The following is a description of a gene set: species: Homo sapiens part of: Gap junction trafficking and regulation Reactome Pathway: Gap junction trafficking Gap junctions are intercellular communication channels formed from Cx (connexin) protein subunits (see Segretain and Falk 2004 and Evans et al. 2006 for comprehensive reviews). Connexins are transported to the plasma membrane after oligomerizing into hexameric assemblies called hemichannels (CxHcs) or connexons. Connexons dock head-to-head in the extracellular space with opposing hexameric channels located in the plasma membranes of neighbouring cells. The double membrane channel or gap junction generated directly links the cytoplasms of interacting cells and facilitates the integration and co-ordination of cellular signalling, metabolism, secretion and contraction. In addition to their role in intercellular communication, connexon hemichannels coordinate the release of ATP, glutamate, NAD+ and prostaglandin E2 from the cells. CxHcs open in response to various types of external changes, including mechanical, shear, ionic and ischaemic stress.<p>The trafficking of gap junctions involves (1) synthesis of connexin polypeptides at endoplasmic reticulum membranes, (2) oligomerization into homomeric- and heteromeric gap junction connexons (hemi-channels), (3) passage through the Golgi stacks, (4) intracellular storage within Trans Golgi membranes, (5) trafficking along microtubules, (6) insertion of connexons into the plasma membrane, (7) lateral diffusion of connexons in the plasma membrane, (8) aggregation of individual gap junction channels into plaques, (9) stabilization of peripheral microtubule plus-ends by binding to Cx43-based gap junctions, (10) internalization of the channel plaque leading to cytoplasmic annular junctions, and (11) complete degradation via lysosomal and proteasomal pathways (see Segretain and Falk 2004). Aspects of gap assembly are described here., and this is the list of marker genes: TUBA4B, GJA1, DNM2, ACTG1, TUBA1A, GJB7, GJC1, GJB4, TUBB3, TUBA4A, TUBA1B, TUBB4B, GJA4, CLTCL1, CLTB, GJB3, CLTA, TUBB8, DNM1, GJA9, GJD3, GJA10, GJA8, GJB6, TUBB8B, TUBB6, TUBAL3, GJB5, GJB2 (NCBI Gene Id 2706), GJC2, TUBB1, ACTB (NCBI Gene Id 60), TUBA8, GJB1, TUBB2B, TUBA3D, AP2M1, DAB2, TUBB4A, GJA5 (gap junction protein alpha 5), GJD2, TUBB2A, GJD4, GJA3, TUBA3E, MYO6, CLTC, TUBA3C, TUBA1C